Given this list of marker genes Ncbp2as2, Cxxc5, Ttc39b, Mgst3, Syt17 (NCBI Gene Id 20984), Mef2c, Mpdz, Olfm1, Scn1b, Ccn3, Aqp4, Resp18, Gabra1, Pcdha4, Tspan5, Nacc2, Sema7a, Stx1a, Serpini1, Schip1, Stmn1, Ptprd, Trp53inp2, Tmem14c, Xlr3a, Neurod2, Adarb1, Auh, Klf10, Uqcr11, Elavl2, Sipa1l2, Bdnf, Cplx1, Mmp16, Tuba4a, Cdk14, Cerk, Hivep1, Acyp1, Ccn2, Stmn2, Uty, Ift20, Glrx3, Fos, Ndrg3, Cadps, Syt2, Nefm, Fgf12, Rala, H1f0, Cd59a, Dio2, Syp, Laptm4b, Fam3c, Mfsd4a, Cryl1, Fbxw7, Gnb1, Osbpl1a, Cdh13, Tbr1, Tmem160, Hypk, Ash2l, Idi1, Fstl1, Bbln, Ackr3, Mobp, Cck, Lmna, Stmn3, Basp1, Id2, Tubb3, Hsd17b12 (NCBI Gene Id 98865), Smap1, Cap1, Bzw1, Acot7, Hspa1b, Fabp7, Adcyap1, Sst, Nr2f1, Ndufc1, Ptgds, Neurod6, Ocel1, Adcy6, Pls3, Ina, Bcat1, Npy, Trpc4, Sh3gl2, Sstr2, here is a description of the gene set: species: Mus musculus from publication McClung CA, Nestler EJ (PMID 14566342) DeltaFosB (a truncated form of FosB) and CREB (cAMP response element binding protein) are transcription factors induced in the brain's reward pathways after chronic exposure to drugs of abuse. However, their mechanisms of action and the genes they regulate remain unclear. Using microarray analysis in the nucleus accumbens of inducible transgenic mice, we found that CREB and a dominant-negative CREB have opposite effects on gene expression, as do prolonged expression of DeltaFosB and the activator protein-1 (AP-1) antagonist DeltacJun. However, unlike CREB, short-term and prolonged DeltaFosB induction had opposing effects on gene expression. Gene expression induced by short-term DeltaFosB and by CREB was strikingly similar, and both reduced the rewarding effects of cocaine, whereas prolonged DeltaFosB expression increased drug reward. Gene expression after a short cocaine treatment was more dependent on CREB, whereas gene expression after a longer cocaine treatment became increasingly DeltaFosB dependent. These findings help define the molecular functions of CREB and DeltaFosB and identify clusters of genes that contribute to cocaine addiction. Genes up-regulated in the nucleus accumbens (a major reward center in the brain) 8 weeks after induction of CREB1 expression in a transgenic Tet-Off system. Mouse Gene Set: MCCLUNG_CREB1_TARGETS_UP